Given this list of marker genes Mmp14, Hspa8, Slc24a4, Cfap69, Cntnap2, here is a description of the gene set: Any process that results in a change in state or activity of a cell or an organism (in terms of movement, secretion, enzyme production, gene expression, etc.) as a result of an odorant stimulus. An odorant is any substance capable of stimulating the sense of smell. studied in species Mus musculus Mouse Gene Set: GOBP_RESPONSE_TO_ODORANT